Given this list of marker genes CACNB3, IL15, IL18BP, CSRP1, ATAD3A, CMPK2, AOAH, IKBKE, WARS1, GMPPB, ANKFY1, PIGU, DNASE1L3, ZBP1, SERPINB9, ASPRV1, POLR1C, SGCB, HERC3, NAMPT, TRIM21, WDR91, RNF213, STAT1, THEMIS2, TMCO4, GBP2, CFLAR, NAA20, TREML2, LRRK1, GBP3, EIF6, NOL9, TBC1D8 (NCBI Gene Id 11138), GATAD2A, PSMB10, RAPGEF2, LGALS3BP, PLAC8, NUDT17, TRIM14, LRP8, ANXA4, RTP4, RASA4, TSPO, DDX54 (DEAD-box helicase 54), RIGI, TSPAN3, C3, SMCHD1, ZC3HAV1, CWC27, ECE2, ICOSLG, FOXRED1, PSME2, SND1, NLRC5, SLC29A3, SETDB2, FSCN1, CXCL9, ABTB2, TLR9, FCGR1A, PPA1, PRF1, SYNGR2, LTBP1, CTSZ, PSME1, PRKCD, TENT4A, TRAF5, TOR1AIP2, IRF7, HELZ2, CLEC2D, PML, EFHD2, LY6S, STRIP2, G3BP2, RNF114 (ring finger protein 114), GOLGA8A, ICAM1, IFIT3 (NCBI Gene Id 8376), SLCO3A1, PSMB9, RNF19B, PHF11, MAP3K8, IL15RA, ADAP1, CD274, TRIM25, ZBTB32 (NCBI Gene Id 27033), ATP10A, MME, HPSE, NUPR1, SLC25A22, KEAP1, CSTB, SAMHD1, MVB12A, NMRAL1, DCP2, OAS2, JAML, RNF31, ATF4, GBP4, SBNO2, CSF1, EPSTI1, POLDIP3 (NCBI Gene Id 84271), ISG15, SLAMF8, STAT3, DDX60, ZFYVE26, CDKN1A (NCBI Gene Id 1026), TRIM26, LGALS9, IRGM, AZI2, PARP14, OGFR, GBP5, SLFN5, STOML1, CNP, CENPJ, HSBP1, ST14, TPST1, CYBA, ATP13A1, MOV10, MLKL, RILPL1, KIRREL1, SDC3, TDRD7, CLCN7, MMP13, CERS6, NKG7, MOSMO, ETV6, EHD4, GZMB, IRF9, CORO1B, TMEM39A, MYD88, PARP12, LGALS3, GPR107, PLIN2, ACOD1, PDE7B, SMCR8, RNF126, IL2RA, MMP14, TRIM5, NOTCH1, NOD1, CCL4, IL12RB1, here is a description of the gene set: from publication Dudziak D, Kamphorst AO, Heidkamp GF, Buchholz VR, Trumpfheller C, Yamazaki S, Cheong C, Liu K, Lee HW, Park CG, Steinman RM, Nussenzweig MC (PMID 17204652) Genes down-regulated in cells from Flt3L Melanom injected mice: splenic DEC205+ dendritic cells versus CD8 T cells. Dendritic cells (DCs) process and present self and foreign antigens to induce tolerance or immunity. In vitro models suggest that induction of immunity is controlled by regulating the presentation of antigen, but little is known about how DCs control antigen presentation in vivo. To examine antigen processing and presentation in vivo we specifically targeted antigens to the two major subsets of DCs using chimeric monoclonal antibodies. Unlike CD8+ DCs that express the cell surface protein CD205, CD8- DCs, which are positive for the 33D1 antigen, are specialized for presentation on MHC class II. This difference in antigen processing is intrinsic to the DC subsets and associated with increased expression of proteins associated with MHC processing. Human Gene Set: GSE6259_FLT3L_INDUCED_DEC205_POS_DC_VS_CD8_TCELL_DN studied in species Homo sapiens